Given this list of marker genes CALM1, PDE6D, UBB, LYPLA1 (lysophospholipase 1), BCL2L1, ABHD17B, USP17L2, FNTB, ABHD17A, ICMT, HRAS, ZDHHC9, NRAS, PRKG2, ABHD17C, GOLGA7, FNTA, UBC, RPS27A, KRAS, UBA52, RCE1, PRKCQ, ARL2, here is a description of the gene set: part of: RAF/MAP kinase cascade studied in species Homo sapiens Reactome Pathway: RAS processing RAS proteins undergo several processing steps during maturation including farnesylation, carboxy-terminal cleavage and carboxymethylation, among others. These steps are required for their membrane localization and function and ultimately for their ability to activate RAF.